The following is a description of a gene set: This is the process of selective removal of damaged mitochondria by autophagosomes and subsequent catabolism by lysosomes. In healthy mitochondria, PTEN-induced putative kinase 1 (PINK1) is imported to the inner mitochondrial membrane, presumably through the TOM/TIM complex. The TIM complex associated protease, mitochondrial MPP, cleaves PINK1 mitochondrial targeting sequence (MTS). PINK1 may be cleaved by the inner membrane presenilin-associated rhomboid-like protease (PARL) and ultimately proteolytically degraded. Loss of membrane potential in damaged mitochondria prevents the import of PINK1 which accumulates on the mitochondrial outer membrane (MOM) of the defective mitochondria. Activation of PINK1 at MOM is achieved via dimerization-mediated trans-autophosphorylation of PINK1 at multiple sites including S228 and S402 (Okatsu K et al., 2012, 2013; Aerts L et al., 2015; Rasool S et al., 2018, 2022; Gan ZY et al., 2022). Activated PINK1 phosphorylates S65 of ubiquitin (Ub) on MOM proteins which leads to increased recruitment of the E3 ubiquitin ligase Parkin (PRKN) to damaged mitochondria (Koyano F et al., 2014; Shiba-Fukushima K et al., 2014; Ordureau A et al., 2015). Activated PINK1 also phosphorylates PRKN at S65 in the N-terminal Ub-like domain inducing the E3 ligase activity of PRKN. Activated PRKN promotes the ubiquitination of mitochondrial substrates including mitofusin 1 and 2 (MFN1, 2) and the voltage-dependent anion channel 1 and 3 (VDAC1, 3). The E3 ligase activity of PRKN generates Ub moieties for PINK1-mediated phosphorylation of Ub thus leading to a feedforward loop in the PINK1:PRKN pathway (Ordureau A et al., 2015; Sauve V et al., 2022). Ubiquitin chains on PRKN-ubiquitinated substrates recruit cargo receptors such as SQSTM1 (p62) and OPTN linking the ubiquitinated substrates to the microtubule-associated proteins 1A/1B light chain 3 (LC3, MAP1LC3) (Heo LM et al., 2015; Lazarou M et al., 2015). The recruitment of both MAP1LC3 (LC3) complexes and the autophagy proteins 5 and 12 (Atg5: Atg12) complex to the autophagosome membrane promotes autophagosome formation. The mitochondrion is engulfed after the isolation membrane grows to a sufficient size to engulf the mitochondrion. Once autophagic vesicle formation is complete, vesicle fusion with lysosomes occurs to form autophagolysosomes in which the lysosomal hydrolases (cathepsins and lipases) degrade the intra autophagosomal content. Cathepsin also degrades LC3 on the intra autophagosomal surface of the autophagic vesicle. species: Homo sapiens Reactome Pathway: PINK1-PRKN Mediated Mitophagy part of: Mitophagy, and this is the list of marker genes: ATG12, ATG5 (autophagy related 5), MFN2, VDAC1, TOMM40 (NCBI Gene Id 10452), UBE2V1, UBE2D3, PRKN, UBE2D2, TOMM5, UBB, UBE2L3, TOMM20, SQSTM1, PINK1, OPTN, MAP1LC3B, UBC, ATG9A, RPS27A, TOMM22, VDAC2, TOMM6, UBA52, TOMM7, MFN1, TOMM70, MAP1LC3A, VDAC3, MTERF3, UBE2N, TBK1 (NCBI Gene Id 29110)